The following is a description of a gene set: Human Gene Set: GSE23321_EFFECTOR_MEMORY_VS_NAIVE_CD8_TCELL_UP An early-differentiated CD8+ memory T cell subset with stem cell-like properties (TSCM) can be identified within the naïve-like T cell population by the expression of CD95/Fas. Based on experiments including exon- and gene-level expression analysis, we provide evidence that this subset of antigen-specific cells represents an early precursor of conventional central (TCM) and effector (TEM) memory CD8+ T cells with enhanced self-renewal capacity and proliferative potential. We identified genes differentially expressed between major T cell subsets defined along with memory T cell commitment. Based on the analysis of these genes, CD95+ naïve T cells (TSCM) cluster closer to the CD8+ T memory compartment than to classical (CD95-) naïve T (TN) cells, and display an intermittent phenotype between classical TN and TCM cells in terms of all major T cell differentiation markers analyzed. Genes up-regulated in CD8 T cells: effector memory versus naïve. from publication Gattinoni L, Lugli E, Ji Y, Pos Z, Paulos CM, Quigley MF, Almeida JR, Gostick E, Yu Z, Carpenito C, Wang E, Douek DC, Price DA, June CH, Marincola FM, Roederer M, Restifo NP (PMID 21926977) species: Homo sapiens, and this is the list of marker genes: ME1, MIR9-1HG, CDX2, PGR, RGS16, GPRC5B, RFXANK, RSC1A1, SYNJ2, CAPN11, PIR, LEPR, CFTR, HMGA2, NKG7, STON1, EFNA3, AFDN (afadin, adherens junction formation factor), DEFA4, ITGB8, MOB4, GRAMD1B, SV2A, ADAMTSL2, RIMBP2, FAP, CYLC1, FZD7, MINK1 (NCBI Gene Id 50488), ITGA4, FGF3, TSPAN8, LY6E, QKI, SCN9A, FARP2, APOBEC3C, MMP7, NFIA, STAB1, NDRG2, KAZN, HPCA, SEMA3F, FAM30A, KRT81, KRT13, ST7, EGR1, LIFR, NCR1, SLC11A2, TCTA, CXCR3, IFNA16, ASCC2, ATP2B1, PLA2G4A, RASAL2, FOXA1, NR5A2, SHBG, LINC00302, IRF6 (interferon regulatory factor 6), ARG2, ICAM4, LAMA4, CYP2C9, BPY2, SMG5, RBPJ, BDKRB1, NGF, PRAF2, CSN1S1, FURIN, ZNF592, DIXDC1, ATP2B4, LMNA, ULK2, SCHIP1, B4GALT6, STARD3, HPS1, AGXT (alanine--glyoxylate aminotransferase), SOCS1, STAM2, SOCS3, CBLIF, HSDL2, HMGXB3, ZNF529, PLIN3, MT1G, SLC10A3, ZNF510, SSPN, TNFSF12, PTPRH, CD84, KCNN3, FADS3, GNAI3, PTENP1, SLC16A5, HECW1, LORICRIN, TFE3, CDIPT, LEPROT, RNF14, GCNT1, DOK1, CCL5, EN2, HOXB13, IL18RAP, CXCL1, POLR1F, MYL3, PIK3C2A, UPK2, NEU1, F7, CHST3, CXCR6, PRDM2, SKIL, DOCK9, SEPTIN10, GRM3, FOXK2 (NCBI Gene Id 84213), CFH, C2orf72, SV2B, NEK3, EPHA1, ZHX3, POU6F1, MPDU1, KIF5A, NOP14-AS1, RAB40AL, SLC7A2, ATF6 (activating transcription factor 6), ENOX2, WASL, CLCN7, RAMP3, CCHCR1, MAG, ASIP, NNAT, VDR, CFAP410, RFPL3S, CMKLR1, NEB, RGS5, VIPR1, MMP13, BEAN1, S100A1, AGT, PTPRZ1, PLA2G4C, GRIN2B, ANKS1A, UCP3, MELK, PPIL2, VAT1, TSPOAP1, GPR45, FCGR3B, APOD, PDE12, CDKL1, MUC5AC (NCBI Gene Id 730855), GALNT2, KLKB1, ALDH1A2, RAB11FIP2, ZNF629, H4C2, PLEK, RGL1, TYMP, DNAH17, CYP2F1, MCAM, PAX7, BASP1, SERPINI2, ARHGEF11, FLNA